Given this list of marker genes RELN, NRXN1, APOE, NLGN1, SHANK3, here is a description of the gene set: The receptor clustering process in which N-methyl-D-aspartate (NMDA) receptors are localized to distinct domains in the cell membrane. species: Homo sapiens Human Gene Set: GOBP_NMDA_GLUTAMATE_RECEPTOR_CLUSTERING